Given this list of marker genes Psmb3, Hras, Malt1, Ighv8-12 (NCBI Gene Id 780960), Rac1, Pak2, Lat2, Tab3, Vav2, Bcl10, Igkv1-88, Ighv8-5, Psmc6, Psmb4, Ighv5-12-4, Mapk9, Ighv8-9, Lyn, Igkv1-99 (immunoglobulin kappa variable 1-99), Map3k7, Ighe, Grap2, Ighv3-1, Ighv5-17, Map2k4, Psmb6, Igkv15-103, Psmd11, Ighv5-9-1, Igkv20-101-2, Psmb1, Mapk10 (mitogen-activated protein kinase 10), Psmd2, Ighv5-16, Psmd3, Ighv5-6, Ighv8-6, Shc1, Ppp3ca, Pik3cb, Psmc3, Lcp2, Ighv5-15, Psma2, Psmc1, Mapk3, Psmd7 (NCBI Gene Id 17463), Uba52rt, Psma6, Nfkb1, Igkv1-110, Psmd14, Igll1 (NCBI Gene Id 16136), Igkv1-122, Igkv17-121, Ikbkg, Ube2v1, Ighv5-4, Ighv8-8, Grb2, Iglc2, Igkv18-36, Psma1, Ms4a2, Vav3, Rps27a, Plcg2, Iglc1, Psmc5, Ube2d2a, Igkv16-104, Skp1, Nfkbia, Igkv1-132, Psmb5, Cul1, Nfatc2, Ighv3-8, Fcer1g, Igkv11-125, Igkv2-109, Nfatc3, Pik3ca, Adrm1, Jun, Igkv1-133, Psma4, Ighv7-2, Ubb, Ube2d1, Ighv3-3 (NCBI Gene Id 668438), Psmb2, Psmd13, Ighv16-1, Ighv5-2, Btk, Lat, Igkv1-135, Tab1, Rela, Fbxw11, Igkv1-35, Itk, Cdc34, Ighv5-12, Fcer1a, Igkv2-112, Pdpk1, Ighv8-11, Ighv5-9, Ube2n, Ighv13-2, Ikbkb, Ighv6-6, Igkv8-21, Igkv1-131, Ighv3-5, Kras, Txk, Pik3r2, Vav1, Ighv3-6, Ighv3-4, Ppp3r1, Ighv7-4, Ubc, Plcg1, Card11, Fos, Nfatc1, Ighv12-3, Calm3, Psmb7, Ighv7-3, Psma5, Calm2, Traf6, Psma3, Ighv8-4, Psmd12, Sos1, Calm1, Syk, Tab2, Psmd1, Map2k7, Psmd6, Ighv6-4, Ighv6-3, Psmc4, Igkv1-117, Ighv6-5, Pik3r1, Igkv2-137, Pak1, Ppp3cb, Psmc2, Psma7, Psmd8, Uba52, Mapk1, Mapk8, Chuk, Ighv8-13, Prkcq (protein kinase C, theta), Ighv8-2, Ighv6-7, here is a description of the gene set: Fc epsilon receptor (FCERI) signaling studied in species Mus musculus Mouse Gene Set: REACTOME_FC_EPSILON_RECEPTOR_FCERI_SIGNALING